The following is a description of a gene set: studied in species Mus musculus Mouse Gene Set: GOBP_THERMOCEPTION The series of events required for an organism to receive a temperature stimulus, convert it to a molecular signal, and recognize and characterize the signal. Thermoception in larger animals is mainly done in the skin; mammals have at least two types of sensor, for detecting heat (temperatures above body temperature) and cold (temperatures below body temperature)., and this is the list of marker genes: Rho, Wdr47, Opn4, Adra2a, Ngf, Cpeb3, Trpv1, Trpm8, Grik2, Trpa1 (transient receptor potential cation channel, subfamily A, member 1)